The following is a description of a gene set: Collagen biosynthesis and modifying enzymes Human Gene Set: REACTOME_COLLAGEN_BIOSYNTHESIS_AND_MODIFYING_ENZYMES species: Homo sapiens, and this is the list of marker genes: COLGALT1, SERPINH1, COL4A5, ADAMTS3, COL11A1, COL4A6, P4HB (NCBI Gene Id 94756), PPIB, COL27A1, COL12A1, COL10A1, COL1A2, COLGALT2, BMP1, COL4A4, COL6A2, COL28A1, TLL2, COL14A1, COL9A2, COL6A6, ADAMTS14, COL5A2, COL4A3, COL4A1 (NCBI Gene Id 1282), COL16A1, COL1A1, COL8A2, COL4A2, COL24A1, PLOD3, P4HA1, PCOLCE2, TLL1, COL6A1, P4HA2, COL19A1, COL25A1, P3H1, P3H2 (NCBI Gene Id 55214), PLOD2 (NCBI Gene Id 5352), COL9A1, COL8A1, P4HA3, PCOLCE, PLOD1, COL3A1, COL5A1, P3H3, COL20A1, COL7A1, CRTAP, COL2A1, COL15A1, COL23A1, COL6A3, COL17A1, COL11A2, COL13A1, COL9A3, COL5A3, COL21A1, COL6A5, COL26A1, COL18A1, ADAMTS2 (ADAM metallopeptidase with thrombospondin type 1 motif 2), COL22A1